The following is a description of a gene set: from publication Schaefer CF, Anthony K, Krupa S, Buchoff J, Day M, Hannay T, Buetow KH (PMID 18832364) studied in species Homo sapiens Aurora A signaling Human Gene Set: PID_AURORA_A_PATHWAY, and this is the list of marker genes: AURKB, CPEB1, PAK1, CKAP5 (cytoskeleton associated protein 5), CENPA, OAZ1, BIRC5, GIT1, TACC3, TP53 (tumor protein p53), PRKACA, FZR1, CDC25B, GADD45A, ARHGEF7, RAN, AURKA, AJUBA (NCBI Gene Id 84962), NDEL1, RASA1, AURKAIP1, TACC1, MDM2, TPX2, GSK3B, AKT1, NFKBIA, TDRD7, DLGAP5, BRCA1, PPP2R5D